Given this list of marker genes TBCE, RBBP8, EIF4E2, RFTN1, MIR155HG, RAC2, ATP1B1, RGS19, GK, MLX, PNKP, KLHL2, NSD2 (NCBI Gene Id 7468), TJP2, DLST, TMT1A, ZBTB8OS, C12orf75, CHST11, TTC9C, DHRS7B, TBC1D2, MRPL47, SRP19 (NCBI Gene Id 6728), TRIB1, MYB, BATF (NCBI Gene Id 10538), LTA, PTPN22 (protein tyrosine phosphatase non-receptor type 22), CDK5 (cyclin dependent kinase 5), MTHFD1L, PPP1R18 (protein phosphatase 1 regulatory subunit 18), NOD2, ERP44, MTHFD1, NAMPT, PLPP1, LRRC59 (leucine rich repeat containing 59), EBP, SEC61B, CTTNBP2NL, KIF3B, SELENOS, NDUFB8, OSM (NCBI Gene Id 5008), ARHGAP21, SC5D, PANX1, FAHD2A, HLF (HLF transcription factor, PAR bZIP family member), SLCO4A1, KAT2B, STING1, HEATR6, CLIC1, SWAP70, BCL2L1, MGST2, ENO1, IDH1, PPP1R16B, MRPL42, ANTXR2, MYL12A, GNA15, TM9SF4, LYRM1, ANXA2, PTTG1, DPP4, YIPF6, LRP8 (LDL receptor related protein 8), SNX10, FRMD4B, SNRPF, DESI2, IRF4, NFKBIE, PDHA1, STK24, BLTP3B, NEDD9, SAT1, HNRNPLL, MYO5A, IL17RB, ELOVL1, GRAMD4, SH3BP5, SIPA1L1, ITPRIPL1, RAB11FIP1, CSTF2, PDE4A, RUNX3, EIF3J, LPP, C4orf46, MAP2K3, AK2, CLDND1, MAF, SGK1, GNG2, BHLHE40, HBEGF, MAP3K8, SMIM30, GCA, RANBP9, CENPJ, IL2RB, PIGX, TNF, STAM (NCBI Gene Id 8027), HDAC9, ADGRE5, SEC23B, TGFBR1, PRDM1, DUSP2, UTP11, SHMT2, SMAD7, TMEM167A, SNHG33, TXNL4A, FOSL2, ATP1B3, RILPL2, CYFIP1, ANXA2P2, UEVLD, TIPIN, PHTF2, TOR3A, ELOC, NCF4, PLAGL2, GPR68, ELOVL5, PKD2, NDUFA6, SLAMF1, TNFRSF9, HK1, WIPI1, IKBIP, DYNLL1, ATG2A, PMCH, FUCA2, TAGLN2, ADAM8, BCAT2, BIRC3, IRAK2, MBD2, COX5A, IKZF4, SOCS2, ETFDH, ATP5MK, PRMT9 (protein arginine methyltransferase 9), EGR3, MAST4, DYNLT2B, TESC, RCBTB2, IL12RB2, LAMTOR2, CTSH, COPS8, CSF2RB, IKZF2, TNFSF12, RTKN2, LAYN, LGALS1, SAP30, SLC39A14, TNFRSF1B, SRPK1, BYSL, TNFRSF18, RALB, TFRC, DBI, PEA15, DMD, SLA2, LDLRAD4, ALOX5, PDE4B, MCTS1, HCST, SNAP47, MYCBP, here is a description of the gene set: studied in species Homo sapiens from publication Bangs SC, Baban D, Cattan HJ, Li CK, McMichael AJ, Xu XN (PMID 19201849) Genes down-regulated in comparison of resting CD4 T cells versus bystander activated CD4 T cells. Human Gene Set: GSE13738_RESTING_VS_BYSTANDER_ACTIVATED_CD4_TCELL_DN There is much evidence that T cells may be activated via mechanisms which act independently of direct TCR ligation. Despite this, the question of whether such forms of ‘bystander’ T cell activation occur during immune responses is hotly debated. To address some outstanding questions, we set up an in vitro system within which to analyse bystander T cell activation in human T cells, in the absence of the possibility for TCR cross-reactivity. In addition, we have investigated the genetic, phenotypic, and functional characteristics of bystander activated T cells. Here, we show that bystander T cell activation is, indeed, observed during a specific immune response, and that it occurs preferentially amongst CD4+ memory T cells. Furthermore, bystander activated T cells display a distinct gene expression profile. The mechanism for bystander T cell activation involves soluble factors, and the outcome is an elevated level of apoptosis. This may provide an explanation for the attrition of T cell memory pools of heterologous specificity during immune responses to pathogens such as viruses.